Given this list of marker genes Gper1, Chrna10, Spry1, Gstp3, Rgs14, Pin1rt1, Lyn, Fbln1, Arrb1, Btn2a2, Sirpa, Lif, Rapgef1, Dynlt1b (NCBI Gene Id 21648), Ezr, Smad4, Ranbp9, Spry2, Dusp26, S2bpcox16, Nlrp12, Igf1, Nlrp6, C1ql4, Sema6a, Gstp-ps, Dusp6, Dusp10, Ptprr, Gstp2, Errfi1, Spred1, Phlpp1, Cav1, Ptprc, Dlg1, E130311K13Rik, Itgb1bp1 (integrin beta 1 binding protein 1), Chrna9, Sirt3, Ptpn2, Spry4 (sprouty RTK signaling antagonist 4), Tlr4, Wnk2, Dusp1, Epha4, Klf4, Synj2bp, Psca, Lmo3, Cnksr3 (NCBI Gene Id 215748), Tlr9, Tnip1, Vrk3, Nherf1, Dusp4, Tbc1d10c, Flcn, Ephb2, Dmd, Adipoq, Dusp29, Rps6ka6, Ptpn1, Dusp3, Xbp1, Ndrg2, Abl1, Dusp9, Emilin1, Phb1, Ace2, Spred3, Gstp1, Pin1, Ankrd26, Spred2, Dab2ip (NCBI Gene Id 98996), Csk, Atf3, Eif3a, Cryba1 (NCBI Gene Id 12957), Dusp7, Dab2, Chrna7 (cholinergic receptor, nicotinic, alpha polypeptide 7), here is a description of the gene set: Any process that stops, prevents, or reduces the frequency, rate or extent of signal transduction mediated by the ERK1 and ERK2 cascade. Mouse Gene Set: GOBP_NEGATIVE_REGULATION_OF_ERK1_AND_ERK2_CASCADE studied in species Mus musculus